Given this list of marker genes Akr1c14, Cyp8b1, Akr1c18, Ptges2, Akr1c6, Ptgs1, Ptgds, Tbxas1, Akr1c13, Akr1c20, Hpgds, Ptgis, Ptgs2, Akr1c21, here is a description of the gene set: Reactome Pathway: Synthesis of Prostaglandins (PG) and Thromboxanes (TX) This event has been computationally inferred from an event that has been demonstrated in another species.<p>The inference is based on the homology mapping from PANTHER. Briefly, reactions for which all involved PhysicalEntities (in input, output and catalyst) have a mapped orthologue/paralogue (for complexes at least 75% of components must have a mapping) are inferred to the other species. part of: Arachidonate metabolism electronically inferred by orthology from the curated human pathway species: Mus musculus